The following is a description of a gene set: Mouse Gene Set: GOBP_MESONEPHRIC_TUBULE_MORPHOGENESIS studied in species Mus musculus The process in which the anatomical structures of a mesonephric tubule are generated and organized. A mesonephric tubule is an epithelial tube that is part of the mesonephros., and this is the list of marker genes: Wnt11, Lgr4, Tcf21, Ctnnb1, Dspp, Nog, Mir216a, Shh, Kif26b, Pax8, Hoxb7, Smad4 (SMAD family member 4), Lzts2, Fgf8, Timeless, Myc, Agtr2, Six4, Agt, Hey1, Fat4, Hs3st3a1, Grem1, Osr1, Hoxd11, Lhx1, Cited1, Fgf2, Wnt2b, Wnt1, Agtr1b, Sox8, Agtr1a (angiotensin II receptor, type 1a), Gata3, Bcl2, Bmp2, Vegfa, Greb1l, Tacstd2, Hs2st1, Fgf1, Foxd1, Pkd2, Six1, Adamts16, Pbx1, Hnf1b, Fmn1, Npnt, Pgf, Gdnf, Smo, Wnt6, Sox9, Gli3, Hoxa11, Maged1, Lama5, Ctnnbip1, Six2, Hes1, Wnt4, Mir216b, Ptch1, Mir217, Pax2, Cd44, Hs3st3b1, Tmem59l, Cited2, Tgfb1, Dchs1, Sall1, Gpc3, Gzf1, Eya1, Wt1, Dlg1, Pspn, Wnt9b (wingless-type MMTV integration site family, member 9B), Ilk, Bmp4 (bone morphogenetic protein 4)